The following is a description of a gene set: MicroRNA network associated with chronic lymphocytic leukemia studied in species Homo sapiens Human Gene Set: WP_MICRORNA_NETWORK_ASSOCIATED_WITH_CHRONIC_LYMPHOCYTIC_LEUKEMIA, and this is the list of marker genes: TP53 (NCBI Gene Id 7157), MIR34B, MIR34C, MIR15A, MCL1 (MCL1 apoptosis regulator, BCL2 family member), BCL2, ZAP70, MIR16-1, MIR34A, ADAMTSL4-AS1